The following is a description of a gene set: studied in species Homo sapiens Human Gene Set: GOBP_NUCLEAR_TRANSCRIBED_MRNA_CATABOLIC_PROCESS_NO_GO_DECAY The chemical reactions and pathways resulting in the breakdown of the transcript body of a nuclear-transcribed mRNA with stalls in translation elongation., and this is the list of marker genes: GTPBP2, TESK1, CNOT6, PELO, HBS1L, CSDE1